Given this list of marker genes Bcl2a1b, Utp18, Bcl2a1d, Slc15a3, Cx3cl1, Csf2, Mpp7, Actg1, Il22, Tnfrsf9, Tgm2, Mapkapk3, Gadd45b, Lilrb4b, Tnfsf4, Mir155hg (NCBI Gene Id 100653389), Pdcd1lg2, Cd83, Atmin, Crem, Hspa5, here is a description of the gene set: studied in species Mus musculus Genes positively differentially expressed in cell type: ILC (innate lymphoid cell) upon treatment with cytokine: IL-36α in mouse lymph nodes in vivo. Cytokines mediate cell-cell communication in the immune system and represent important therapeutic targets. A myriad of studies have highlighted their central role in immune function, yet we lack a global view of the cellular responses of each immune cell type to each cytokine. To address this gap, the authors created the Immune Dictionary, a compendium of single-cell transcriptomic profiles of more than 17 immune cell types in response to each of 86 cytokines (>1,400 cytokine-cell type combinations) in mouse lymph nodes in vivo. A cytokine-centric view of the dictionary revealed that most cytokines induce highly cell-type-specific responses. For example, the inflammatory cytokine interleukin-1β induces distinct gene programmes in almost every cell type. A cell-type-centric view of the dictionary identified more than 66 cytokine-driven cellular polarization states across immune cell types, including previously uncharacterized states such as an interleukin-18-induced polyfunctional natural killer cell state. from publication Cui A, Huang T, Li S, Ma A, Pérez JL, Sander C, Keskin DB, Wu CJ, Fraenkel E, Hacohen N (PMID 38057668) Mouse Gene Set: CUI_ILC_IL36A_RESPONSE_UP